Given this list of marker genes Stx12, Ulk2, Bcas3, Atg2b, Wipi2, Rb1cc1, Atg7, Atg5, Rab1b, Becn1, Stbd1, Atg2a, Ulk1, Tax1bp1, Wipi1, Sqstm1, Nbr1, Zfyve1, Wdr45, Atg14, Atg13, Atg101, Rab7, Atg16l2, Ulk3, Atg12, Snx30 (NCBI Gene Id 329860), Wdr45b, Becn2, Atg9b, Vmp1, Snx7, Atg16l1, Atg9a, Phaf1, Pik3c3, Ilrun (inflammation and lipid regulator with UBA-like and NBR1-like domains), Atg3, here is a description of the gene set: species: Mus musculus Mouse Gene Set: GOCC_PHAGOPHORE_ASSEMBLY_SITE Punctate structures proximal to the endoplasmic reticulum which are the sites where the Atg machinery assembles upon autophagy induction.